The following is a description of a gene set: species: Mus musculus Cytokines mediate cell-cell communication in the immune system and represent important therapeutic targets. A myriad of studies have highlighted their central role in immune function, yet we lack a global view of the cellular responses of each immune cell type to each cytokine. To address this gap, the authors created the Immune Dictionary, a compendium of single-cell transcriptomic profiles of more than 17 immune cell types in response to each of 86 cytokines (>1,400 cytokine-cell type combinations) in mouse lymph nodes in vivo. A cytokine-centric view of the dictionary revealed that most cytokines induce highly cell-type-specific responses. For example, the inflammatory cytokine interleukin-1β induces distinct gene programmes in almost every cell type. A cell-type-centric view of the dictionary identified more than 66 cytokine-driven cellular polarization states across immune cell types, including previously uncharacterized states such as an interleukin-18-induced polyfunctional natural killer cell state. Genes positively differentially expressed in cell type: cDC1 (conventional dendritic cell type 1) upon treatment with cytokine: IL-7 in mouse lymph nodes in vivo. from publication Cui A, Huang T, Li S, Ma A, Pérez JL, Sander C, Keskin DB, Wu CJ, Fraenkel E, Hacohen N (PMID 38057668) Mouse Gene Set: CUI_CDC1_IL7_RESPONSE_UP, and this is the list of marker genes: Bcl2a1b, Lgals3bp, Apol7c, Ly6e, Ppa1, Flot1, Coro2a, Cxcl16, Spi1, Irf5, Cd300a, Zbp1, Pim1 (proviral integration site 1), Isg15, Cxcl9, Casp4, Trim30a, Socs1, Serpina3g, H2-K1, Irf7 (NCBI Gene Id 54123), Pfn1, Usp18, Cst3 (NCBI Gene Id 13010), Ccnd1, Cdkn1a, Sri, Ier3, Ctsz, Ccdc86, Bcl2a1d, Ms4a4c, Actr3, Slfn5, Cdc14a (NCBI Gene Id 229776), Apobec3, Ifi205, Cd40